Given this list of marker genes RIOK2, TMED1, DDX19B, BRINP2, TANC1, INTS7, BCL2L1, WDR6, TMEM70, CARF, ARMH2, APPBP2, FRMD4B, NDUFAF1, TCP1, CREB1, KCNJ5-AS1, ARHGAP25, PLEKHS1, MIR298, PSD2-AS1, PPFIA3, VTA1 (vesicle trafficking 1), RNU5E-1, IL1R1, BPGM, MTF2, COX6B1, SLC28A2-AS1, MARS1, TBL1XR1, SEMA3A, RPS11, HIBADH, NEMP1, BUB1, FLVCR1, CDHR3, DNAH10 (NCBI Gene Id 55921), UQCRC2 (ubiquinol-cytochrome c reductase core protein 2), NOCT, LIMS2, FKBP10, ENSG00000243953, TBX2-AS1 (TBX2 antisense RNA 1), CA1, EXTL2, EGLN2, SEMA4B, AOPEP, GET3, RNA5SP21 (RNA, 5S ribosomal pseudogene 21), GSPT1, HTR1A, MITF, DSP, KDM2A, CLN8, RNF220, ACACA, PABPC4, PALLD, LINC02123, PGBD5, ELOC, MEIS2 (Meis homeobox 2), BSCL2, ZNF56P, GRPEL2, PWWP3A, WIPF2, GPR183, SNRPD1, TMEM40, RPL21, SNHG3, COMMD10, CHST7, JOSD2, RPL15, DIXDC1, SFRP5, GBA1, HIRIP3, SMARCAL1, LSM8, ZNF614, EIF4G2, UBB, FAM229B (NCBI Gene Id 619208), VTRNA1-1, PIH1D1, ALG1L2, PCAT7, FER1L6-AS1, RIPK2, SOX2-OT, BLZF1, MPV17L2, RPPH1, CBLB, PPP2R2B, SPPL2A, TRIM11, GABARAPL2, PHB1, ZNF346, MIR5680, CHD2, ZNF277, SLC5A1, HADHA, ID4, SRSF5, KDM3A (NCBI Gene Id 55818), SLC35B4, TGFBR2, PEX19, EIF4A2, RPL32P27, SREK1, HSD17B10, GRIP1, TUBD1, PHIP, YKT6, EGLN3P1 (NCBI Gene Id 100420503), RPL17, NRXN1, HSPD1, SKA2, ETS2-AS1, FIP1L1, APOBEC2, ZBTB4 (zinc finger and BTB domain containing 4), PRPF4, ANKRD42-DT, PELI3, SLC37A4, GIT2, WDFY3, CACNA1C, CAMK2D, MAPDA, RNF186, PFKP, COG5, SAMD4B, FBXO24, PPRC1, CA14, NUDT4, SLC30A3, CCDC32, ERBB3, GIGYF2 (NCBI Gene Id 59281), RILP, NDUFA13, FASTKD2, SPATC1L, H4C2, RPL22L1, SARS2, EMSY, DPCD, RWDD1, PAX6, GNL1, POLDIP3, SESN2, EIF3F, COL14A1, STRIP1, ZFHX3, NFIA-AS1 (NFIA antisense RNA 1), ZNF785, MCCC2, ATPSCKMT (ATP synthase c subunit lysine N-methyltransferase), GC (NCBI Gene Id 2638), H4C3, TOP1MT, SNORD71, MTBP, SPAST, MYL12A, MIR22HG, KCNQ1, RDUR, DYNC2I2, MIR7973-2, ANGEL2, TLR5, ABHD16A (NCBI Gene Id 7920, abhydrolase domain containing 16A, phospholipase), RBM5-AS1 (NCBI Gene Id 100775107), SNORA13, SCHIP1, ATP2B4, KLHL4, SLC8A1, CSNK1A1, SLC16A1, ERCC1, R3HDM1, SHB, KIF20A, MYH6, GDAP1, NUP42, FAM174B, CEP44, SLC25A38, SMC3, SZRD1, ITGB5, FAM32A (NCBI Gene Id 26017), RNU5E-4P, ARMH4, ACAA1, AP3D1, POLR2A, BCL9, CEACAM16-AS1 (CEACAM16, CEACAM19 and PVR antisense RNA 1), TSC1, USP41P, RGS8, G3BP2, RNF167, TRIM55, MARCHF7, NUP88, LINC02709, DNM1L, DNAJC8, ZNF225, CDC40, IFT43, CLCNKA, GAPDHP53, PRPF38A, GNAS, PRKACA, HRGP2 (HRG pseudogene 2), DCTD, RNA5SP161, NKIRAS1 (NFKB inhibitor interacting Ras like 1), ZNF790, CELSR1, ARAP1, RPE (ribulose-5-phosphate-3-epimerase), METTL17, RPL7, THAP1, NAMA, CAPN15, RN7SKP134, ALPK2, NIPAL1, LARGE1, PDE7B, DOCK5, ANAPC10, PPME1, VMP1, FAM219B, TBCD, PPIL2, DCAF6, FGGY-DT, PCYT1B, TMEM144, PYGM, FLAD1, CDCA3, PIK3AP1, MTFR1L, NAB1, SESN1, AEBP2, LTBP2, VGLL4, ENSG00000275765, TFDP2, CRACR2A, ARHGEF28, YJU2B, COQ3 (coenzyme Q3, methyltransferase), SLC2A2, MRPS27, NAA50, ZBTB17, MLLT1, CMTM7, MYNN, PPP1R12B, MARCOL, METTL3, SLC35A4, LRRC51, RANBP10, NOD1, TJP1, CLIP1, SRRT, CMSS1, BRD9P2, FAM53C, KBTBD2, ENSG00000255647, SYVN1, TTC32-DT, BZW2, JUP, SH3BGR, TNPO1-DT, ACOX2, NFKBIZ, PSMD1, RPL7L1P8, AARSD1, C1orf174, PSD3, GTF2IP20, PFKFB2, TMT1B, TMCC3, CLRN3, NPPA, RNF187, AP4B1, ARL6IP5, PKP4, MSL2 (MSL complex subunit 2), TBC1D4, IL23R, VPS39-DT, PLK3, KIF14, FBXO8 (F-box protein 8), TMEM230, BCORL1, SLC4A1AP, BCL11A, CCDC18-AS1, EIF2B5, TMEM63C, ADORA1 (NCBI Gene Id 134), SNHG16, ZBED5-AS1, SLC12A7, SDCCAG8, ALDH1A2, SNORD42B, SFXN5, MED24, MDH1B, VPS25 (vacuolar protein sorting 25 homolog), CDK6, ABCA5, TENM2, ZRANB2-DT, HSPE1-MOB4, ZNF672, LTBP4, ZNF48, NUMA1, TACC2, CYP27A1, NUP62CL, TNFAIP2, OSBPL10, MTREX (NCBI Gene Id 23517), NBPF3, MLIP, NOL4L, CTNND1, GANC, AGR2, PMS1, CREB3L2, SIRT4, ANXA6, MIGA1, HSPA1A, RPL32P3, BCAS3 (BCAS3 microtubule associated cell migration factor), TMEM109-DT, SVEP1, ACP3, AP3S1, TICRR, ARHGAP1, PLSCR1, TMEM244, ITGB3BP, WDR45, ZNF815P, MSH5-SAPCD1, EPCIP-AS1, MBTD1, SPICP4, ULK4, SGCB, ADNP2, SSR3, CFAP57, C16orf95-DT, OSGEPL1-AS1, ODAD4, GUF1, MIR548AW, TRIP10, MIR4729, NARS2, CRYBA2, TCTN1, LNPK, ARL14EP, EIF2B4, PRR3, FBXW11, NCOA4, XPC-AS1, RPL7L1, IREB2, NDUFA11, HSPB7, EIF3K, SLC25A11, ATP1B3, CDH17, KAT5, MYBPHL, NUFIP2, NAA38, ORC1, CYB5B, TIMM9, FAM185BP, FAM227A, PTK2, PTP4A3, MRPL27, MTF1, BUD31, ACSS3, NRDC, KIAA0319, HMG20A, COQ5, ZNF773, EXOSC5, CSNK2A1, DONSON, ZNF763, TACO1, TTC13, PLCG2, MTOR, DCAF11, RBBP5, POLR1A, RDH10, FSD2, AKAP9 (A-kinase anchoring protein 9), PSMB5, MFF-DT, IMP4, EXOC8, RABGGTB, CNPY4, SGPL1, ERICH1, PPFIA1, NCOA5, BANCR, POLR1G, C1QTNF4, SEPTIN7P13, KIAA0586, EP400P1, CYCS, APPBP2-DT, CCNB1IP1, TTF2, MYOM1, RNU4-40P, CTSB, ENSG00000258231, IFT74, CDIN1, ITGB6, MYL3, NR4A3, P4HB, SPRTN, CCDC13, DTHD1, ATP6V1G2-DDX39B, MRPL11, C12orf76, BMP5, RGS5, AMOTL2, FAM98B, CDCA2, ZFP90, ARL4A, MIR5087, SELENOP, PCNX4-DT, TMEM167B-DT, EDNRA, C2CD3, SULF1, CDK5RAP2, WDR74, MCEE, MON1B, FBXO38, PROSER2-AS1, FRMD3, RTN4R, NECTIN3-AS1, NNMT, GOLM2, HAVCR2, AQP4, MIATNB, SCN5A, BCKDHA, NMRAL1, MIR548AP, FILIP1, DPYSL3, ASH2L, CCDC162P, ENSG00000266401, ZNF236, CHPT1, DPP9, MPPE1, MICALL1, SH3BP4, FASTK, TSTD2, HDAC8, ENSG00000255491, RBM26, VPS13B-DT, MIR9-1HG, OXA1L-DT (NCBI Gene Id 105370404), PARP1, DLGAP1-AS1, ZNF608, SERTM2, UFSP2, SP1, KIFAP3, CHEK1, RPLP0P10, DCLRE1B, LRFN5-DT, YOD1, CLDN7, COX7A2L, TTC28, ERP44, OBSL1, RAB5A, MTIF3, ANKRD11, TCF3, CCDC148, TNK2 (tyrosine kinase non receptor 2), RNU6-169P, CCDC107, CNOT1, LINC00663, VPS13B, KDM8, TMEM67, FUZ, MAPK14, USO1, SPEG, CATSPER2P1, NAPEPLD, AMD1, RPL17-C18orf32, BAHCC1, PHLDB1, LTB4R2 (leukotriene B4 receptor 2), ANXA2R-AS1, URI1, WASF1, PRR13P5, RNU6-704P, TENT5C-DT, LINC00903, RASAL2-AS1, PTCD3, SIPA1L1-AS1, LINC00964, FAM117A, DACT1, SASH1, GLCCI1-DT, PIPOX, TP53, LINC00900, GABARAP, FGFR1, ZSCAN22, RACGAP1, TMEM202-AS1, EPC2, ITFG2-AS1, EME1, MYLK3, SLC46A3, ZNF613, ZCCHC8, UBLCP1, CAST, PARAIL, ITPRID2, MRPL24, SLC12A8 (solute carrier family 12 member 8), ANKRD50, RNVU1-15, SETD7, CCDC15, PBX1, DHX38, AP1M1, TMEM51, GNAI2, TXN, MAGI3, SMG7, ALG10, TSG101 (tumor susceptibility 101), KHDC4, PNN, PIK3C2A, BNC2, ZNF542P, MAP3K13 (mitogen-activated protein kinase kinase kinase 13), CIDEB, IFT140, NUDCD3, ZNF565, NF2, ENSG00000246308, FSTL4, RFT1, ADAM22, RNF103, VIPAS39, P3H2 (NCBI Gene Id 55214), RXRA, PSMC1, ZMYM4, RAI14, LINC01066, LDHB, FRAT1 (FRAT regulator of WNT signaling pathway 1), MAP4K1, VLDLR-AS1, MRPL13, DIRC3, SLC34A2, BBS9, ATP13A4, STK11IP, TOM1L2, PGAP3, RNASEH2C, IL9 (interleukin 9), PSMD10, RUBCNL, ZBED5, C16orf95, POPDC2, RERE, E2F3, SCP2, SIRT2, HROB, ZNF503-AS2, ZNF764, HIGD2A, LONP2, PRR11, CYB5D1, LIN28A, THG1L, S100Z, LINC02319, MCM3, NCKAP5-AS1, TESK2, ITFG2, CHEK2, PIM1, LINC03048, GID4, PIH1D2, NUP153, TNKS1BP1, NDUFB1, PDLIM1, TBC1D9B, CFDP1, GGA1, BICD1, PDE12, UTP18, FOXJ2, ZNF225-AS1, CDK6-AS1, CUEDC2, GTPBP10, MAP4K4, NIPBL, MIR133A1HG, COPS7A, PARVA, ZNF486, COPS4, LINC02362, RBM24, PSEN2, PPP1R13L, TCEAL8, JPT2, EGF, HAGH, MIR4757, NGDN (NCBI Gene Id 338007), CEP57L1, POLE3, SMG5, ATP5PF, ESRRG, MC4R, ITCH, SESTD1, SLC9A1, EFCAB7, PPP6R3, TACC1, ABHD17B, NDUFAF4P1, CHD3, KCTD9, EBNA1BP2, APTX, IDH3A (isocitrate dehydrogenase (NAD(+)) 3 catalytic subunit alpha), CWC15, HAPSTR1, UGP2, WDFY3-AS2, HDGF, EFR3B, ONECUT1, ABAT, TNNT2, SMG7-AS1, ANKDD1B (NCBI Gene Id 730805), LYZL4, SUN1, EDEM1, CDC26, SETDB2, RBCK1, PDAP1 (PDGFA associated protein 1), TRMT11, ZNF143, CLN5 (CLN5 intracellular trafficking protein), SWSAP1, DM1-AS, ANKRA2, LRRIQ3, SORT1, NKAPD1, ACTR5, ZNF266, MALAT1, ALOXE3, C9orf85, CDADC1, NCAPD3 (NCBI Gene Id 23310), SYNPO2L, ZRANB2, SF3B5, ATPAF2, BCAR1, SNORD101, RNF125, CCDC88C, MRPL18, LCMT2, HDAC4, STIM1, SPSB4, ENSG00000237429, BBIP1P1, CD81, CASP8, EGR2, ZNF268, CMAHP, RN7SL571P, LINC03021, HSCB, PITPNA, KIAA1671, FCHO2, SEMA3C, AP3S2, ASB2, BBOX1, AP3M2, CCN2, TSACC, CPSF2, EIF2B5-DT, ST3GAL5, VMAC, SORD, STARD4, GATAD2B (NCBI Gene Id 57459), PLD1, SAE1, RNF145, RRAS, UPF2, NDUFB3, RUNX1T1, VAMP4, SH2B1, INKA2, BAMBI, SH3RF2, RHBDD3, LINC01134, ASAH1, C1orf105, HOMER2, BCO2, PRPF31, ARHGEF3, EHMT1, PFKP-DT, TMEM223, SLC2A8, HBP1, DYNC1LI1, ARMH1, DDI2, HS3ST5, TSSK6, CYSRT1, GINM1, AXL, ATP6V1A, WRAP53, UBAC2, TRA2A, PSMD8, LINC00882, MCF2L, EXOC4, RHOC (NCBI Gene Id 389), ALDOA, RNF157, ADK, PLEKHA7, ENSG00000236426, DDX21, PRADC1, SRP54, SPIRE1, ST6GALNAC2, WASF2, GREB1L, COA1, GSDMD, LINC02172, FAM161B, TCAM1P, ATG101, ZNF827, SSR2, PANK3, LINC02320, STAT2, SPARC, RNU2-17P, TMEM63B, SHC1, TRIM35, ZNF217, STAT3, PSKH2, MTMR14, MARCHF1, ATXN7L1, MED4, UBXN7-AS1, NAPSA, SLC25A37, GARS1, MTIF2, ARV1, LINC02216, UIMC1, DERL1, CCDC117, PSMA3, TFEB (NCBI Gene Id 7942), OXSR1, ERCC2, GAPDHP25, EFCAB14, CHD1, RNU7-124P, FRG1, SNAP25, NEBL, TRIM7-AS1, MKKS, GPR61, RCC1, GORASP1, PDPN, RBM39, MED8, RPS6KB1, MFSD11, DHRS11, C4orf36, LINC02474, UXS1, GUCD1, JCHAIN, PRKAR1A, RPL18A, ZNF443, NAV2-AS2, P3H4, EDA2R, FBLN1, PTCH1, RALGAPB, MIX23P5, AFF1, CCDC141, EMC4, RPN2, ASAH1-AS1, MFF, FNIP2, MRPS30, PHACTR4, SLMAP, NRL, TTC21A, SNHG4, ACYP2, TUT1, SVIL, ZNF687, CS, HNRNPA3P16, GSK3A, CENPU, HSPBP1, RHEX, CFL1, PRMT5-DT, CTIF, YIF1A, KAT7, EMC7, PLIN2, NXN, EPB41L4A-AS1, RPLP1, STK40, H3C6, ZNF622, ENC1, KLF6, CNPY2-AS1, PDCD4, NPAT, PTK2B, PRR14, ASF1B, NFRKB, TBC1D8 (TBC1 domain family member 8), SNHG32, LINC01278, INO80E, RPL27, ZFYVE27, GRM7-AS3, RNA5SP360, CALM2, C19orf38, SPECC1, RNU12, MPC2, GFI1B (growth factor independent 1B transcriptional repressor), KHSRP (NCBI Gene Id 8570), CYB5R1, BRCA1, HMGCR, DOCK2 (NCBI Gene Id 1794), RRN3P1, ZC3H15, TEX2, ATP5MC3, MYBPC1, ZBTB8B, SSBP1, TUFM, TPI1P2, ACVR2B, MMRN2, MACIR, C1QTNF1-AS1, CRPPA, BRK1, SDHD, EBAG9, PEAK1, RNASE4, LINC00910, CFLAR-AS1, RNASEH2B-AS1, CRTC2, ACTR1A, MATR3, SNORD48, MLH1 (mutL homolog 1), UBR2, ACLY, ITPRID2-DT, ZC3H11A, SLC40A1, RHOBTB2, WEE2-AS1, SOS1, PGR, TAF6, GATAD2A, PPFIBP2, SPINK5, KDM4D, RPS27P16, RNU5A-1, FBXO38-DT, TRAJ50, PCMTD1, GIT1, LINC02889, CD101-AS1, CDH8-AS1, CCDC115, UNC45B, TAF15, HERC2, SNF8, SLC38A8, DCAF8, TIMM8B, IL17RC, WNT5A, TFPT (TCF3 fusion partner), TRAJ41, BACH1, LINC01232, MCEMP1, COX16, SCUBE2, CCDC146, EVA1A-AS, TMEM204, LINC00339, TTC7B-AS1, CLIC1, PXN-AS1, TEFM, ZFYVE26, EFHB, USP45, CAB39L, ADD1, UBE2S, BRD8, DISC1, RAMAC, GPR19 (G protein-coupled receptor 19), ABCB8, SKIDA1, OTUD3, GCNT2, ZNF678, PWWP2A, SLC44A3-AS1, HACD2, MRPL42P6, SNORD95, BPNT1, UQCC6, MROH8, RPL7AP35, MIR17HG, PARP2, PRKCI, TARBP2, ZDHHC4, ZNF724, ATP6V1G2, PDZRN3, BCAR3, CSF1, UQCRQ, PKN3, DAAM1, RPAIN, DOCK9, MYH7B, ERI3-IT1, GPR153, EPM2AIP1, HSPE1, KNL1, LINC00881, TXNL4B, UTP3, C10orf90, CBX5, EFCAB2, FAHD1, SERPIND1, TSNAXIP1, POLL (DNA polymerase lambda), CLDN4, ESYT1, PLEKHA1, LINC02985, SNX17, ZNF146, GAB3, ENG, CCNC, MUS81, CPVL, CEP170, MRPS16, ATG4A, TMEM79, ZSCAN16, SLC22A13, CDC42EP5, PMVK, LINC00649, PRMT5, NEU1, NOP16, STARD10, PDE4D (phosphodiesterase 4D), HIBCH, NCKAP1, PDXDC2P-NPIPB14P, ULK3, FDXACB1, IFNAR1, SREBF2-AS1, LIMCH1, MIR181A2HG, MAGEL2, GBE1, RPUSD2, PLOD2, ERI2, AREG, RACK1, TTN, G3BP1, CTDSP1, ATG16L1, PDE4C, TMEM200B, SLX4IP (NCBI Gene Id 140682), RPLP0, ADGRD1, CCDC124, PLBD1, ATP6V1D, DCTN4, GABPB1, RERE-AS1, RPL37, CCT5, PCBD2, ABR, LARS1, DLG4, CDK5, ADAP2, FHIP1B, ZNF503, MTCH1, BOD1, NUMB, HYCC2, SNORA24B, OXA1L, RPF1, LL0XNC01-250H12.3, TMCC2, C11orf21, XPOTP1 (exportin for tRNA pseudogene 1), LRP2, RPS12, KIF26B, RNU6-746P, SEC23IP, SORBS2, ADAMTS3, FEM1B, ARHGEF37, KPNA6 (karyopherin subunit alpha 6), GDF2, CKS1B, UBR1, MIB2, TDH, STAG3L3, MRPS12, SUPT7L, XPC, SLC35E1, GPR108, ST3GAL6, METTL15, ARPC2 (NCBI Gene Id 220721), MRPS14, AFF3, MRPS30-DT, TAF11, GYG1, LINC01034, STAU2-AS1 (STAU2 antisense RNA 1), EHBP1, DNAJA1, MSS51, ZCCHC2, NHSL1, PDCD7, TRPM7, TTLL13, ZDHHC7, CSNK1D, SLC16A7, YARS1, ARMH3, EEF2, NME7, MAP1S, ADGRL1-AS1, GPX6, IFI27L2, RGMB, SNORD45C, MRPL3, LINC01900, CAP1, ZFYVE16, ZFYVE1, CNIH4, ACACB, ORMDL1, GABPB1-AS1, ABHD10, C2CD5, HRC, SCYL3, AP2S1, TTC1, ZNF79, VARS2, RPL22, ATM, PDE9A, FTO, CHD1-DT, NLGN1, UTP15, CEP20, SMIM15, PGBD4, NR2F2, VPS39, ANG, TCEANC2, MED7, ANXA2R, BLTP1, AKAP11, RNU1-8P, HDAC2-AS2, CCDC65, EPOR, ARHGAP32, MARCHF11-AS1, PLXDC1, RNU11 (NCBI Gene Id 26824), DHX8, RNU5E-6P, GREP1, ARHGAP24, NCKIPSD, ZNF112, PPP1R35, TRIM5, EMSY-DT, GLCCI1, LSG1, PIGP, ADAMTS7P4 (ADAMTS7 pseudogene 4), COPS2, PAXBP1, LINC02248, ATXN2L, NME5, RGS10, HOXB6, RNF43, DAG1, CCDC174, LINC01338 (NCBI Gene Id 102546175), NCALD, LDB3, ATP5MC2P4, GOLGB1, MIA2-AS1, PPP2R5B, ZFP36L1, RPRD2, MIR592, GANAB, RPL21P18, TNPO3, CXXC4, IGFL4, ACVR2A, STRN4, ACIN1, ZNF143-AS1, MAP3K12, GNAL, MALSU1, LINC00970, ENSG00000236846, SNORD58B, USP7, SPPL3, TSC22D1, LINC01431, ETV4, ANKRD42, ANP32E, CASD1, INSYN2B, ANKRD6, ST3GAL3, FANCA, VAMP2, TMEM108 (transmembrane protein 108, NCBI Gene Id 66000), PPCDC, NECTIN3, LINC01554, FRYL, INTS1, GIPC1, TAX1BP1-AS1, TOMM40, CEP120, HUS1, CENPF, ATG2A, AKTIP, ZNF345, HSPB1, DRAIC, CDC42BPB, MBTPS1, REXO5, ELP2 (NCBI Gene Id 55250, elongator acetyltransferase complex subunit 2), SNORD1C, RAD18, WDR24, ENSG00000250781, PHF12, DNAAF6, PUS10, DDX6, TP53BP1, MCC, RUNX2, GTF2H4, ZBTB18, ENSG00000231964, DAGLB, ACP6, SLC36A4, ZNF879, SEMA4F, NXT2, SH2D5, SLC39A1, PSMC3, ORAI3, SLC4A5 (solute carrier family 4 member 5), NDUFA4, RPUSD3 (RNA pseudouridine synthase D3), LINC02955, ZNF862, PLEC, C19orf48P, LINC00938, GCSIR, P2RX6, RBM41, ATG12, ZNF688, POU6F2, PCNX4, ASPH, LINC00365, TMEM59, LUCAT1, TMEM109, YAP1, CREBL2, JPT1, SZT2, RARB, ZNF408, ZNF45, CYMP, ACSF3, TXNIP, ZNF3, FCHO2-DT, WDR70, PCMTD1-DT, STRA6, MBNL1-AS1, FBH1, ENSG00000227741, SPATA41, FOXP1, IQCE, SPOP, ARIH1, RNU7-195P, NDUFA12, EIF5B, CBY1, PRSS23, SRGAP2, RPL23A, RASAL2, NFKBIB, MYL4, ARRDC3, RSBN1, LIPE-AS1, DLG5, EML6, NUP205, UBXN6, CREB3L4 (cAMP responsive element binding protein 3 like 4), RAPGEF4, MAP3K4-AS1, WWP2, TAF1B, MEF2C, ERBB2, DELE1, TSPAN3, ENO3, HEG1, KIF18A, SNRPD3, TTC32, ELMO1, TBC1D19, BMAL1, MICAL3, MSH5, SRCAP, PRPSAP1, RMRP, INTS4 (NCBI Gene Id 92105), PAFAH2, CALCRL, DLGAP5, NFKBIL1, ZRANB3, RNU6-547P, GLRX2, ATP1A1, RTRAFP2, NUP155, ERAP1 (endoplasmic reticulum aminopeptidase 1), RNU6-398P, FEM1A, GPR39, ABLIM2, DHX29, FBXO16 (NCBI Gene Id 157574), RAB28, MYLK-AS1, SERINC5, GALK2, ENSG00000259737, STARD13, GLUD1, PRCC, VCPIP1, CFAP107, RNA5SP324, EWSR1, OR8B9P, FBXL20, TMEM102, TENT5C, ENSG00000261335, PLA2G6, DMXL1, ARL14, OSGEPL1, SRI, HNRNPC, INHA, NDRG1, CCT3, NOS3, ARRDC4, PITHD1, CCT7, ZFAND6, AP3M1, CDK12, TSC22D4, ACTC1, CFAP68, RAPGEF4-AS1, EIF2S1, PIK3R1, EPAS1, PDGFRA, CLDND1, CUTA, EIF5A, APBB3, LINC01409, MAP2K5, SLC4A2, SATB1, SMIM10L2A, AHSA1, ETFBKMT, INVS, LRCH4, GDF9, CHRNB1, SDCBP, RTL5, PANK1, SPRED1 (sprouty related EVH1 domain containing 1), PSMA6, NPM1P29, SELENOH, MIR7843, here is a description of the gene set: Human Gene Set: NKX2_5_TARGET_GENES Genes containing one or more binding sites for (NKX2-5) in their promoter regions (TSS -1000,+100 bp) as identified by GTRD version 20.06 ChIP-seq harmonization. species: Homo sapiens from publication Yevshin I, Sharipov R, Kolmykov S, Kondrakhin Y, Kolpakov F (PMID 30445619)